Given this list of marker genes OPTN, PIGG, PUS1, BTK, PCMT1, TPP2, IL2RA, PPIP5K1, DHDDS, GABRB2, CBFB, RPAP1, FXYD5, AKIP1, PPARD, MBD3, NTHL1, LYPLA1, SMC1A, HDHD5, RTL8C, STARD7, HNRNPA0, AKAP1, METTL18, MGA, TECR, NUP155, FBP1, FAT1, SELENOP, AIMP2, ANXA1, NOC3L, MTSS1, TEX30, ILKAP, OGFOD1, PSMD1, UQCRC2, GASK1B, AVEN, UNC119B, SEC61G, MYC, MTO1, RAD1, RTCA, UTP11, YWHAH, C17orf75, C6orf120, ALAS1, SPCS1, SQLE (squalene epoxidase), SKAP1, DCAF6, OCLN, HSPE1, TMSB15B, RPS27, SIAH1, NELFCD, MCCC2, TTC4, PSMA4, CD36, LPIN1, ERCC2, YTHDF2, WDR74, CLTC, PRPS1, POLR3C, GOLGA8A, SRP9, PAN2, SS18, FOLR2, DMXL1, RFX7, LSG1, BANF1, CSTPP1, NUP133, LARS1, POLG, TBC1D2B, AGGF1, DDOST, ERGIC3, NOL7, MRPS22, TUBB3, RTCB, RARS1 (NCBI Gene Id 84715), ERP29, POLR2G, MRPL23, SSR4, NDRG2, MRPL12, ALDH1A1, THG1L, AGPAT5, PTGES3, GRB10, MRPS34, ZC3H14, ANAPC5, HES2, LRRC47, MYO1D, TUBG1, RIOX2 (NCBI Gene Id 84864), RRBP1, HERC1, QPRT, EIF2B3, SRI, GNE, USP12, HLA-DPA1, SLC30A1 (solute carrier family 30 member 1), FAM171A1, ENDOD1, POLR3E, NKAPD1, NENF, YTHDF1, ENOPH1, INPP5F, MPG, NOLC1, PDE4A, TGFBI, NHP2, UPF3A, NDUFA8, GALNT2, LYRM2, STK25, MAPK9, ACKR2, ABCE1, ATP13A1, TGS1, CDC40 (cell division cycle 40), NF2 (NF2, moesin-ezrin-radixin like (MERLIN) tumor suppressor), SOCS5, DET1, AKR1B1, AFP, CRYZ, YARS1, NAE1, CSE1L, PAAF1, CCNC, CCT5, ACVR1, TAF1D, FKBP3, ROBO3, ABRAXAS2, TCF12, MRPL34, PNMA1, CEP72, FIBP, AKAP12, LAX1, DIABLO, MYOT, FGA, WDR7, AP2B1, PIK3CB (NCBI Gene Id 5291), RNFT1, BSCL2, CAMTA1, SLC27A2, CD151, PID1, SEH1L, FAM136A, NAT10, PDXDC1, UBE2V2, CTSL, ENOSF1, ERI3, RPL13A, CKS2, EIF2AK3, ATF1, MNAT1, NDUFB8, PRP4K, here is a description of the gene set: species: Homo sapiens In the present study we used Affymetrix oligonucleotide microarrays to produce gene transcription profiles for the major leukocyte types in humans. This comprehensive dataset enabled us to not only establish which genes were expressed in each leukocyte type, but also which genes were expressed in each subset after activation. The used of a comprehensive dataset of gene profiles from all the major human leukocyte subsets enabled a novel and powerful means for identification of genes associated with single leukocyte subsets, or different immune paradigms. Human Gene Set: GSE3982_MAST_CELL_VS_NEUTROPHIL_UP Genes up-regulated in comparison of mast cells versus neutrophils. from publication Jeffrey KL, Brummer T, Rolph MS, Liu SM, Callejas NA, Grumont RJ, Gillieron C, Mackay F, Grey S, Camps M, Rommel C, Gerondakis SD, Mackay CR (PMID 16474395)